The following is a description of a gene set: studied in species Mus musculus Genes with intermediate-CpG-density promoters (ICP) bearing histone H3 K27 trimethylation mark (H3K27me3) in embryonic stem cells (ES). Human Gene Set: MIKKELSEN_ES_ICP_WITH_H3K27ME3 We report the application of single-molecule-based sequencing technology for high-throughput profiling of histone modifications in mammalian cells. By obtaining over four billion bases of sequence from chromatin immunoprecipitated DNA, we generated genome-wide chromatin-state maps of mouse embryonic stem cells, neural progenitor cells and embryonic fibroblasts. We find that lysine 4 and lysine 27 trimethylation effectively discriminates genes that are expressed, poised for expression, or stably repressed, and therefore reflect cell state and lineage potential. Lysine 36 trimethylation marks primary coding and non-coding transcripts, facilitating gene annotation. Trimethylation of lysine 9 and lysine 20 is detected at satellite, telomeric and active long-terminal repeats, and can spread into proximal unique sequences. Lysine 4 and lysine 9 trimethylation marks imprinting control regions. Finally, we show that chromatin state can be read in an allele-specific manner by using single nucleotide polymorphisms. This study provides a framework for the application of comprehensive chromatin profiling towards characterization of diverse mammalian cell populations. from publication Mikkelsen TS, Ku M, Jaffe DB, Issac B, Lieberman E, Giannoukos G, Alvarez P, Brockman W, Kim TK, Koche RP, Lee W, Mendenhall E, O'Donovan A, Presser A, Russ C, Xie X, Meissner A, Wernig M, Jaenisch R, Nusbaum C, Lander ES, Bernstein BE (PMID 17603471), and this is the list of marker genes: ZEB2, PRSS16, UPK3A, CNN1, LEP, SFTPC, ALPI (alkaline phosphatase, intestinal), PLEKHG4, ZIC4, CFAP57, NEURL3, POU6F1, TMEM255A, RNF112, DUSP8, TNF, HPCA, KCNG4, RTBDN, MC3R, KCNJ9, CYP8B1, FXYD7, MZB1, PCDHB6, MYH11, TNNC2, ADCY6, PARVG (NCBI Gene Id 64098), HOATZ, CHST1, PDE6B, XIRP1, COL24A1, TLR9, UTS2R, CPLX3, CALCB, NKX2-6, LRRTM3, LRRC4B, OPTC, TH